The following is a description of a gene set: from publication Schaefer CF, Anthony K, Krupa S, Buchoff J, Day M, Hannay T, Buetow KH (PMID 18832364) studied in species Homo sapiens Human Gene Set: PID_IL8_CXCR1_PATHWAY IL8- and CXCR1-mediated signaling events, and this is the list of marker genes: GNB1, PRKCG, LYN, ARRB1, ARRB2, PIK3R6, PLD1, GNAI2, PDPK1, GNA15, GRK2, CBL, HCK, PIK3CG, GNA14, PRKCE, PRKCA, CXCL8, CXCR1, RAB5A, DNM1, AKT1, PRKCB, PLCB1, FGR, PLCB3, PLCB2, GNG2